The following is a description of a gene set: species: Mus musculus Mouse Gene Set: chr2C3, and this is the list of marker genes: Gm26408, Gm13653, 8430437L04Rik (RIKEN cDNA 8430437L04 gene), Gm14424, Gm13674, Osbpl6, Rps6-ps4, Chrna1, D230022J07Rik, Dnajc10, Hspe1-ps5, Gm4735, Pjvk, Dusp19, Zfp385b, Gm13667, A330043C09Rik, 6430710C18Rik, Gm18494, Map3k20, Gm13652, Gm24461, Ube2e3, Chn1, Atf2, Prdx6b, Cdca7, Pde1a, 4930441J16Rik, Hoxd11, Cir1, Hoxd8, Chrna1os, Neurod1, Ift70b, Nup35, Gm13688, Gm13752, Rapgef4os2, Ift70a1, Plekha3, Mtx2, Mrpl23-ps1, Gm13700, Gm13650 (NCBI Gene Id 102638671), Ppp1r1c, Ola1, Gm13755, Nckap1, Gm13689, Hnrnpa3, Gm13651, Mir684-1, Sestd1, Haglr, A630050E04Rik, Gpr155, Gm13660, Cerkl, Gm37004, Hoxd1, Gm13673, Atp5mc3, Gm14465, Itprid2, Pde11a, Gm13668, Hoxd3os1, Sp9, Rapgef4os3, Rbm45, Cyct, Prkra, Gm25420, Gm14464, Ttn (NCBI Gene Id 99250), Gm13687, Gm22652, Frzb, Gm14460, Gm13944, Sp3os, Gm13690, Nfe2l2, Gm22606, Gm14425, Ift70a2, Evx2, Lnpk, Wipf1, Eif1-ps3, Ccdc141, Scrn3 (NCBI Gene Id 99245), Gm14427, Cwc22, Gm13655, Itga4, Hoxd9, Gm14461, 2600014E21Rik, Gm13658, Sp3, Gm13657, Gm13649, E030042O20Rik, Fkbp7, 4930445N08Rik, Agps, Gm13669, Gm13756, Gm13726, Hoxd12, Gm13707 (predicted gene 13707), Pex13-ps, Hoxd3, Gm17014, Hoxd10, Chn1os3, Hoxd13, Gm13666, Mir10b, Gm13665, Ak3l2-ps, Gm13709, Rapgef4os1, Hoxd4, Pdk1, Rapgef4